The following is a description of a gene set: from publication Dik WA, Pike-Overzet K, Weerkamp F, de Ridder D, de Haas EF, Baert MR, van der Spek P, Koster EE, Reinders MJ, van Dongen JJ, Langerak AW, Staal FJ (PMID 15928199) species: Homo sapiens Human Gene Set: GSE22601_DOUBLE_NEGATIVE_VS_IMMATURE_CD4_SP_THYMOCYTE_UP T cells develop from progenitors that migrate from the bone marrow into the thymus. Thymocytes are subdivided roughly as being double negative (DN), double positive (DP), or single positive (SP), based on the expression of the CD4 and CD8 coreceptors. The DN stage is heterogeneous and can be subdivided into four distinct subsets in mice based on the expression of CD44 and CD25. In human, three distinct DN stages can be recognized: a CD34+CD38−CD1a− stage that represents the most immature thymic subset and the consecutive CD34+CD38+CD1a− and CD34+CD38+CD1a+ stages. Human DN thymocytes mature via an immature single positive (ISP CD4+) and a DP stage into CD4+ or CD8+ SP T cells that express functional T cell receptors (TCR) and that exit the thymus. In this study, gene expression was measured in each of these nine stages. Genes up-regulated in double negative thymocyte versus immature CD4 single positive cells., and this is the list of marker genes: TMEM14C, TMEM192, KMT5A, STX8, SYNJ2, SYNJ2BP, SLC4A5, VIM (vimentin), ZNF621, SNORD42A, SETDB2, TAS2R46, RNASET2, SLAIN2, RNF145, SET, SEC14L1, TNFSF8, VRK2, TMEM14A, U2AF1, ZNF484, PRPS1, TKT (transketolase), SLC25A3, RGL2, TMEM9B, TRUB1, REEP3, SRI, SUGT1, SPMIP8, SRCIN1, TSPYL5, SLC25A45, SLC4A1AP, PPP4R2 (protein phosphatase 4 regulatory subunit 2), TRAV8-3, TOR1A, SUZ12P1, UBE2I, SUMO3, SNX19, ZNF70 (zinc finger protein 70), SMARCA4, SNORD54 (small nucleolar RNA, C/D box 54), TBC1D4, TWSG1, TAMM41, SMYD3, TCIRG1, UROS, ZNF473, USP20, ZNRD2, ZCCHC14, SRSF12, ZNF417, SNX25, TBC1D20, SMC4, ZNF808 (NCBI Gene Id 388558, zinc finger protein 808), RAB3GAP1, RPN1, RALGDS, SP1, ZBED5, SNORA33, ZNF148, SNX15, ZNF592 (zinc finger protein 592), RAD54L2, SETD5, ZNF879, TNIP2, PPP1R15A, SNORA5A, PRDX4, TOMM20, STAM2, ZYX, TLE4, ZNF749, STK11IP, PPP1R26, SKAP1, SH3GL1, RPL27, RBM44, MRM3, ZNF714, TAF12, SLC39A1, TRIM38, ZBTB34 (NCBI Gene Id 403341), ZSCAN12, TSPYL4, PRUNE1, PSMA1, ZNF91, RXYLT1, ZNF45 (zinc finger protein 45), ZNF773, THAP4, SGMS1, XRN1 (NCBI Gene Id 54464), XPA, SPPL3, RAB39B, RRP1B, RAP1GAP2, ZNF106, RNF34, EMC6, RAB34, THOC7, RTTN, NEMP2, SNORA14B, S1PR1, SH3BP5, SACS, TAX1BP1, UNC119B, TPST2, PPP1R9B, UAP1L1, SEC22B, SNW1, SMU1, ZNF781, SOD2, SYTL3, SNX5, RXRA, TMED9, VCL, SNORA54, TMEM231, RAB5C, SLC22A20P, SPAG7, TAF1L, SPI1, SIAH1, PYCARD, TXN, UPP1, SLC39A3, ZRANB1, PRDX3, SPATA20, SLC35A1, TSEN2, SCARNA6, PPP4C, RPS6, XRCC5, PTS, TXNL1, TXNDC16, TXNDC15, ZNF705A (zinc finger protein 705A), ZNF841, SLC35F2, UQCR11, PPP1R18, RAD51B, TMEM237, SESN2, PUS7, PTBP1, TRMT2A, SP3 (Sp3 transcription factor), SESTD1, ZNF672, UFD1, PIP4P1, RIC8B, RSBN1L, WWC3, TRA2A, SPRYD7, TUBA1B, SORBS3, PRKCD, SHISA7, ZNF85, RMND1, RIF1, UBR7, TCF12, ZNHIT6, ZIC1, RCCD1, PRMT2, TBCEL, RTF1, RHBDF2, ZER1